The following is a description of a gene set: Genes up-regulated in hepatocellular carcinoma (HCC) induced by overexpression of MYC. Human Gene Set: LEE_LIVER_CANCER_MYC_UP species: Homo sapiens Genetically modified mice have been extensively used for analyzing the molecular events that occur during tumor development. In many, if not all, cases, however, it is uncertain to what extent the mouse models reproduce features observed in the corresponding human conditions. This is due largely to lack of precise methods for direct and comprehensive comparison at the molecular level of the mouse and human tumors. Here we use global gene expression patterns of 68 hepatocellular carcinomas (HCCs) from seven different mouse models and 91 human HCCs from predefined subclasses to obtain direct comparison of the molecular features of mouse and human HCCs. Gene expression patterns in HCCs from Myc, E2f1 and Myc E2f1 transgenic mice were most similar to those of the better survival group of human HCCs, whereas the expression patterns in HCCs from Myc Tgfa transgenic mice and in diethylnitrosamine-induced mouse HCCs were most similar to those of the poorer survival group of human HCCs. Gene expression patterns in HCCs from Acox1(-/-) mice and in ciprofibrate-induced HCCs were least similar to those observed in human HCCs. We conclude that our approach can effectively identify appropriate mouse models to study human cancers. from publication Lee JS, Chu IS, Mikaelyan A, Calvisi DF, Heo J, Reddy JK, Thorgeirsson SS (PMID 15565109), and this is the list of marker genes: RPL36, CISH, CYP7A1, RNASE4, RPS14, GSTM1, CDCA3, RPL13AP5, RPLP2, FDFT1, SLC22A1, RACK1, LY6D, CSTB, CCN2, LCN2, MCM6, SLC13A3, CSRP2, SLC1A4, LECT2, SNTB1, RPL13A, HMGCS1, PALMD, PLAT, GSTM2, PDGFC, CYP26A1, ACTG1, NUSAP1, SLC1A2, HTATIP2, LPL, LY6E, CCN1, DCLRE1A, MGST3, KIF20A, RPL28, IDH3A, FBXO21, CDK1, RALB, RPL12, APRT, RPS16, MAT2A, DMPK, GLUL, RPS24, TMEM176B, TPR, CTSE